The following is a description of a gene set: studied in species Homo sapiens Human Gene Set: GOBP_ER_NUCLEUS_SIGNALING_PATHWAY The series of molecular signals that conveys information from the endoplasmic reticulum to the nucleus, usually resulting in a change in transcriptional regulation., and this is the list of marker genes: TMCO1, AKT1, ATG10, ATAD3A, BOK, NFE2L2, QRICH1, RPAP2, ABCA7, SELENOS, AMFR, TP53, PPP1R15B, CREBZF, SREBF1, SPRING1, MANF, PTPN1, PTPN2, AKT2, ATF4, MIR96, ATF6, ZBTB7B, SREBF2 (sterol regulatory element binding transcription factor 2), SCAP, GSK3B, EIF2S1, ERLIN1, ERLIN2, NCK1, INSIG1, MBTPS1, AGR2, EIF2A, XBP1, DDIT3, WFS1, PAQR3, TMEM33, INSIG2, NCK2, PPP1R15A, HSPA5, DDRGK1, EIF2AK3, ATP2A2, CCDC47, FBXW7, ARHGEF10L, ATF6B, AKT3, TMED2, MBTPS2